The following is a description of a gene set: N-glycan trimming and elongation in the cis-Golgi Human Gene Set: REACTOME_N_GLYCAN_TRIMMING_AND_ELONGATION_IN_THE_CIS_GOLGI species: Homo sapiens, and this is the list of marker genes: MAN1A2 (mannosidase alpha class 1A member 2), MAN1C1 (mannosidase alpha class 1C member 1), MAN1A1, MGAT1, MANEA